Given this list of marker genes ESF1, RPL10, TAF1D, RGL1, TRIB1, SECISBP2L, ECHDC1, MTMR6, CDK10, TGFBR3, ELOVL5, ZCCHC10, NRBF2, ORC4, MECOM, DHCR7, ZNF226, GCH1, LEPROT, IRF9, SAT1, ZNF330, TEX30, WDR13, FNDC3B (NCBI Gene Id 64778), NFYA, UGCG (NCBI Gene Id 7357), RAP2C, TNFAIP8, MOSPD1, RGS4, CHMP2B, ZBED5, GTPBP8, AIMP1, RO60, PDCD10 (programmed cell death 10), PRPF18, POT1, CALD1, EXOSC8, DNAJC24, ING3, KLHL22, RABGGTB, ACE2, ARFGAP2, BCAS2 (BCAS2 pre-mRNA processing factor), CGRRF1 (cell growth regulator with ring finger domain 1), RABGAP1L, RAB11FIP2, HNRNPDL, SLC5A3, SH3GLB1 (SH3 domain containing GRB2 like, endophilin B1), CD44, DUSP1, TP53I3, HEY1, CTBP2 (NCBI Gene Id 87435), ASPH, ARHGAP29, AMD1, MSMB, DKK1, NACC2, TGIF2, CXCL8, TRAK2 (trafficking kinesin protein 2), CCNL1, NOL11, BTBD1, CEBPZ, SLC29A2, TCEAL4, VAMP7, RYBP, SOX4, ERI2, ZMYM4, SYNJ1, TM7SF2, STAG1 (NCBI Gene Id 10274), RRAS2 (NCBI Gene Id 22800), ACBD3 (acyl-CoA binding domain containing 3), MSX2, THOC1, SHLD2, ATG12, LAMTOR3, PTGS2, ZNF410, CDK7, MOB4, ACTR6, APRT, MFF, PNN, TXNDC9, BAG1, DCTN6 (dynactin subunit 6), AFG3L2, ID2, TMEM100, CDC42EP3, NOC3L, HAT1, EPB41L2, NDUFV1 (NCBI Gene Id 4723), RNF187, CDK1, RBM34, NAE1, UBE2V2, NDEL1, CCNH, ZNHIT6, PDGFC, PPIC, EEF1E1, PLEKHF2, TP53BP2, ATG5, N4BP1, CCL20, ANKHD1, CETN2, LDLR, AK6, IVNS1ABP, LSM8, SEPHS2, C6orf120, FUT4, PTPRK, KLF6, WWTR1, INPP5F, C1orf115, SELENOP, GCNT1, PCYT2, NR1H4, MTIF2, UQCRB, NAP1L1, GAMT, here is a description of the gene set: Human Gene Set: PUIFFE_INVASION_INHIBITED_BY_ASCITES_DN from publication Puiffe ML, Le Page C, Filali-Mouhim A, Zietarska M, Ouellet V, Tonin PN, Chevrette M, Provencher DM, Mes-Masson AM (PMID 17971902) At least one third of all cases of epithelial ovarian cancer are associated with the production of ascites, although its effect on tumor cell microenvironment remains poorly understood. This study addresses the effect of the heterologous acellular fraction of ovarian cancer-derived ascites on a cell line (OV-90) derived from the chemotherapy-naïve ovarian cancer patient. Ascites were assayed for their effect on cell invasion, growth, and spheroid formation. When compared to either no serum or 5% serum, ascites fell into one of two categories: stimulatory or inhibitory. RNA from OV-90 cells exposed to selected ascites were arrayed on an Affymetrix HG-U133A GeneChip. A supervised analysis identified a number of differentially expressed genes and quantitative polymerase chain reaction validation based on OV-90 cells exposed to 54 independent ascites demonstrated that stimulatory ascites affected the expression of ISGF3G, TRIB1, MKP1, RGS4, PLEC1, and MOSPD1 genes. In addition, TRIB1 expression was shown to independently correlate with prognosis when its expression was ascertained in an independent set of primary cultures established from ovarian ascites. The data support the validity of the strategy to uncover molecular events that are associated with tumor cell behavior and highlight the impact of ascites on the cellular and molecular parameters of ovarian cancer. studied in species Homo sapiens Genes down-regulated in OV-90 cells (ovarian cancer) exposed to ascites which inhibited invasion.